Given this list of marker genes EDNRA, AQP1, CD34, ADGRF5, RHPN2, TMEM63C, GAS6, F2R, CORO2B, ADORA1, TTR, IGHA2, PPP3CA, F2RL1, XPNPEP3, JCHAIN, COMT, TBC1D8B, UMOD, IGKV3-20, CYBA, EMP2, SULF1, MYO1E, PDGFB, KIRREL1, SULF2, IGHA1, EDN1, PTPRO, GJA5, NPHS2, ITGA3, MCAM, here is a description of the gene set: studied in species Homo sapiens Human Gene Set: GOBP_RENAL_FILTRATION A renal system process in which fluid circulating through the body is filtered through a barrier system.